The following is a description of a gene set: Genes containing one or more binding sites for (Hand1) in their promoter regions (TSS -1000,+100 bp) as identified by GTRD version 20.06 ChIP-seq harmonization. Mouse Gene Set: HAND1_TARGET_GENES studied in species Mus musculus from publication Yevshin I, Sharipov R, Kolmykov S, Kondrakhin Y, Kolpakov F (PMID 30445619), and this is the list of marker genes: Tbc1d9, Gm7985, Mgat4a, Sp2, Rock2, Smad7, Atp6v0d1 (ATPase, H+ transporting, lysosomal V0 subunit D1), Ppp1r11 (NCBI Gene Id 76497), Pierce2, Tubgcp3, Sde2, Foxp1, Fbxl21, Gm16576, Tubd1, Man2b2, Kpna2, Mat2b, Mecom, Dnah9, Prorsd1, Nebl, Nck2, Stk10, Akr1b1, Rpl37, Shld1, Mir6403, Slit3, Specc1, Gm5547, Suclg2, Traf3ip2, Slc46a3, Gm15704, Cdc42ep4, Osbp, Hdnr, Slc12a4, Mrpl4, H3f3b, Birc6, Gm10532, Dnmt1, Gm5532, Tnfaip1, Pabpc4, 2810013P06Rik, Rps3a1, Sowahb, Atp6v0e, Arhgap23, H4c16, Nudt9, Fam117a (NCBI Gene Id 215512), Gm14055, D030040B21Rik, Ccng2, Tbx3, BC028471, Ppm1h, Capzb, Dyrk2 (dual-specificity tyrosine phosphorylation regulated kinase 2), Chst14, Rora, Osbpl2, Tdrp, Limk2, Ska1, Zmynd8, Sumf2, Bcas3os1, Stk38, Tnfrsf14, Lrrn2, Nkx6-3, Serpinb9, Pcm1, Alpk2, Gnb1l, Sema4d (NCBI Gene Id 20354), Marveld2, Gm3830, Cxxc4, Ddc (NCBI Gene Id 13195), Ddhd2, Ct55, Uhrf1, Kif13a, Rarres2, Cers4, Tmem144, Pbx1, Ahcyl1, Primpol, Polr3gl, Tmem205 (NCBI Gene Id 235043), Ankrd10, 2610005L07Rik, Gm15441, Hykk (hydroxylysine kinase 1), Snord118, Gtpbp1, Mapk3, C130073F10Rik, Tfb1m, Ucp2, 1810008I18Rik, Adamts3, Cacul1, 5830437K03Rik, Tmc6, Gse1, Lrtm1, Mir3091, Slc1a4, Rps21, Scd2, Ccdc159, Dand5, Mcub, P4ha2, Adm, Acacb (acetyl-Coenzyme A carboxylase beta), H4c14, Nkx2-9, Vipas39 (NCBI Gene Id 77895), Col9a1, Ccdc40, Fhip2a, Gm29642, T2, Msl2, Plin3, Impdh2, Gosr2, Abcf2, Lexis1, Phf14, Ppp3ca, C530005A16Rik, Ints9, Gm5444, Acads, Platr22, Rassf1, Myocd, Cygb, Klhl6, Ndufa4, Ppig, Rad51ap1, Mapre2, Desi1, Atg13, Spindoc, Gm19744, Fscn1, Nudt16l1, Sirt2, Zfp975, Ptprs, Cpt1b, Zfp119a, Lamb2 (NCBI Gene Id 270417), Wnk4, Mapk8ip3, Ccdc42, Cdk19, Cdk7, Ccdc134, Gm9968, Gmip, Hoxd12, Arid1a, Efcab14, Ociad1, Por, Cinp, Ttc9c, Clasrp, Sh2d5, Mxra8, Pias3, Rnf186, Zfp446, Meis2, Colgalt1, Slc3a2, Kifc3, Pank3, Gpr19, Gm12089, Dnajb5, Tfpi, Atp1a1, Grk4, Mrpl40, Cd24a, Trappc2b, Mir3069, Zmym6, Cdv3, Mapk8ip2, Gm16283, Flywch1, 1700028E10Rik, M6pr, Prxl2a, Stx6, Spata24, Mlec, Zfp142, 2810405F15Rik, Spring1, Guca2a, Rhoc, Tead1, Zfp410, Tatdn2, Lrrn4, Gm25541, Sdhaf4, Adcy7, Gm42918, Mmp2, Mideas, Gm17484, Fbxl12, Cdh2, Egfl7 (EGF-like domain 7), Usp36, Foxd3, Lin28a, Cirbp, Ephb4, Kcnd3os, Tor1aip2, Tubb2a, Ppcs, Ticam1, Hmgn1, Ing3, Poc5, Sspnos, Osr2, Gm16084, Ube2d-ps, Coq8b, Gm10222, Stam, Dhx36, Tm7sf2, Bmpr1a, Dhx38, Limk1, Gm36535, Rab18, Tmbim1, Vgll4, Syt14, Lrrc27, Esyt2, Rps6ka1, Eci2, Rfc1, Gm34144, Vrtn, Tppp3, Pgam5, Nedd4, Rab11fip1, Mir1938, Cox10, Popdc2, Nfam1, Gm25894, Gm25855, Socs7, 2900052N01Rik, Dcaf11, Tmem231, Col4a4, Brms1, Ttc8, Tnpo2, Slc26a11, Plekhb1 (NCBI Gene Id 27276), Cpsf4l, Spout1, Tbc1d16, Gm266, Pcdhgc4, Carm1, 2610028E06Rik, Tbx3os1, Kank1, Vps53, Txnl4b, Gnao1, Uba6, Gm12198, Bag1, Gnai2, Mrpl48, Slc7a7, Txnip, Slc30a2, Rcan1 (regulator of calcineurin 1), Ift20, Slc30a7, Cip2a, Asphd2, Gorab, Prr11, Zfp622, 1700030K09Rik, Stmnd1, Gm24046, 4833413E03Rik, Lrrfip2, Mfap1a, Alyref2, Pitx2, H3c6, Olfml3, Syt2, Cpa2, Myl12b, Zcwpw2, St6galnac6, Adck2 (aarF domain containing kinase 2), Rbck1, Gm11335, Tagln3, Atox1, Klhl2, Prtg, Dusp6, Ubtd1, Ephb3, Minpp1, Tsku, Bcl7c (NCBI Gene Id 233901), Mfsd14b, Tarbp2, A330015K06Rik, Ddost, Aph1b, Plgrkt, Mybl2, Zbtb20, Abi3, Acsl6, Ddr1, Iqca1, Cacna1c, Kmt5a, Eef2k, Ifrd1, 4930434B07Rik (NCBI Gene Id 73973), 4930458D05Rik, 4933439C10Rik, Rab3il1, Svep1, Rassf8, Ccpg1, Pdlim3 (PDZ and LIM domain 3), Tmem132a, Pcp4 (NCBI Gene Id 18546), A730013G03Rik, Itpr2, Fam168a, Ank3, Gm16070, Mpo, Aasdhppt, Cmtr2, Nim1k, Dop1b, Pecam1, Tbx18, Ripply1, 1700052H01Rik, Egf, Chd2 (chromodomain helicase DNA binding protein 2), Mir8104, Myo6, Rnd3, Sun2, Mir3092 (NCBI Gene Id 100526525), Ska2, Ap1g1 (adaptor protein complex AP-1, gamma 1 subunit), Rpl27, Apeh, Gm38250, Ube2v2, B230217O12Rik, Zc3hav1l, Gm3716, Tmc3, Eny2, Rapgef4, Tbc1d14, Marchf2, Grid2ip, Gm5421, Hpcal4 (NCBI Gene Id 215010), Rab34, Bmf, Cald1, Ggt5, Adnp, Ccdc47, Smg9, Clpb, Rap2a, Intu, Selenom, Gm4491, Surf6, Mprip, Mycn, Pgm1, Ankzf1, Dlc1, Smad6, Kcnd2, Rnft2, Kif17, 2610027K06Rik, Rdm1, Irx3os, Idi1, Hmgxb3 (NCBI Gene Id 72314), Eef1g, Fgfr3, Tmem104, Tmem62 (transmembrane protein 62), Junb, Efna1, Zdhhc17, Lsp1, Prob1, Pcdhgc3, Tiprl, Gadd45g, Prokr1, Slk, Gm16120, Mylk3, Atad1, Cibar2, Hoxd11, Nutf2, Zmiz1os1, 2310022A10Rik, Mrpl51, Ddx20, U2surp, Cks1b, Ppp4r3b, Hes1, Hmgb2, Wdr76, Rab13, Zswim4, Gm15458, Tnc, BB218582, Tnnt2, Kdm4a, Ypel2, Ppp2r3d, Mvb12a, Ctc1, Eloc, Tuba1b, Plpp1, Lig4, Ccdc17, Dhx32, Harbi1, Phf19, Zkscan1 (NCBI Gene Id 97269, zinc finger with KRAB and SCAN domains 1), Spmip8, Aldh9a1, Npc2, Ddx42, Rps6kb1, Pdlim4, Ints14, Gdf3, Ccdc150, Blvrb, Rgs3, Ppp1r3e, 1700031F10Rik, Pnpla8, Dkk1, Llgl2 (LLGL2 scribble cell polarity complex component), Thnsl1 (NCBI Gene Id 99364), Gngt2, Cgrrf1, Tmem126b, Nfatc3, Bnip3l, Otud4, Zfp36l2, Fam229b, Masp1, Pja2, Stra6, Pelp1, Prickle3, Traj12, Phf23, H2-K2, Il19, H4c8, Mtg1, Gpx4, Spint2, Slfn14, A930019D19Rik, Ptpru, Isca2, Ppp1r15a, Schip1, Gpx1, Tlcd3a, Tomm20, Hif1a, Mug1, Txn1, Mcur1, Zmat2, Ampd3, Fbxl3, Scp2, Yjefn3, Igfbp4 (insulin-like growth factor binding protein 4), Gm10463, Apoo (NCBI Gene Id 73714), Fbf1, Gm24452, Unc5c, Sh3glb1, Vwa5b1, Colq (NCBI Gene Id 382864), Lrp1, Chid1, D6Wsu163e, Fzd7, Lix1, Vkorc1l1, Rbpms, Prss28, Ripor3, Ppp1r42, Rassf2, Septin9, Gm29340 (predicted gene 29340), Vapa, Chmp5, Sptbn4, Eml6, Dpf3, B9d1os, Rgs5, Cage1, Atg9a, Ednrb, Epm2aip1, Cgnl1, Enkur, Zfp395, C920006O11Rik, Gng8, Pan3, Aplnr, Nfkbib, Fndc11, Pes1, Magi3, Zkscan17, Cfap20, Gbp10, Zkscan5 (zinc finger with KRAB and SCAN domains 5), Eya3, Zscan21, Gm14488, Gm13421, Gm15688, Ifitm1, Hnrnpul2, Lgals3, Nr1d1, Zfp655, AA914427, Bcs1l, Smim5, Gm24061, Gm10101, Zfp638, Xrcc6, Gm11532, Gm29480, Elp5, Fam90a1b, Bivm (NCBI Gene Id 98474), Igsf10, Gm14703, 9830144P21Rik, Scarb1, Tars1, Gm11476, Tent4b, Shc1, Lca5l, Chst7, Mdk, Rcor2, Ccn2, Sp4, Pcgf2, Ddx41, Klhdc10, Stk11ip, Rps27l, A630052C17Rik, Gip, Ubr1, A930028O11Rik, Nsg2, Mms19, Ubl5, Crtc2, Gm12688, Rrp1b, Aqp10-ps, Arl4d, Nop14, Gm14453, Plekha7, Dlg4, Mapkap1, Mib2, Mir762 (microRNA 762), Extl2, Dzip3, Shroom1, Zmynd12, Abhd4, Cdc37l1, Alpl, Atp8b3, Aspscr1, Banp (BTG3 associated nuclear protein), Pgap3, Hmbox1, Fam13a, Cars2, Vwf, Gja1, Ndufa13, Atic, Ablim1, Adcyap1r1, Gcdh, Asah1, Gm9888, Rps27, Slc25a51, Pde4d, Gm11827 (predicted gene 11827), Psma6, Ogdh, Kbtbd3, 2810001G20Rik, Prkcz (protein kinase C, zeta), Agrn, Adgra2, Ctdnep1, Actr2, Ncald, Ncapd2, Tmem88, Tspan33, 4931415C17Rik, Ttc29, Ksr1, Nat9, Dad1, Polr2j, Vdac3, Aloxe3, Srsf9, Nktr, Fam110d, Hira, Nfat5, Klhdc8b, Mlh1, Cmklr1, Mir7238, Gm7008, Tnks1bp1, Pld3, Pla2g6 (NCBI Gene Id 53357), E330040D14Rik, Sgms1, Stmn1, Gm20052, Hes6, Uggt2, Bcas3, Rpusd2, Gm12976, Zfp946, Pde4c, Gzf1, Tube1, Lzts1, Frmd6, Gls, Rubie, Oaz1, Xpo6, Dpp6, Hhatl, Unc13a, Dhx8, Ncoa4, Rasgrp3, Gm10544, Riiad1, Acad12, Spaca6, Casp3, Dnm1, Slc30a3, Ahsa1, Edrf1, Top1, Herpud2, Mtrf1l, Hsf2bp, Hdac5, Id1, Runx1t1